The following is a description of a gene set: Mouse Gene Set: GOBP_POSITIVE_REGULATION_OF_CELL_ADHESION Any process that activates or increases the frequency, rate or extent of cell adhesion. studied in species Mus musculus, and this is the list of marker genes: Megf10, Stx3, Ccr2, Hrg, Flna, Ccl19 (NCBI Gene Id 24047), Il2, Dock8, Ptpn23, Pdgfb, Itga6, Cd59b, Pawr, Egflam, Cited2, Sash3, Cd209d, Col8a1, Cxcl12, Cd160, Cd209e, Ldb1, Selenok, Vav1, Sirpa, L1cam, Cd47, Map4k4, Hyal1, Icosl, Ephb4, Ptger4, Lilrb4b, Ccl21a, Rac1, Anxa1, Il15, Ep300 (E1A binding protein p300), Carmil1, Il1b, Dsg2, Kat5, Stat5b, Lep, St3gal4, Cd80, Edil3, Pbrm1, Hspd1 (heat shock protein 1 (chaperonin)), Dnm2, Lif, Tnf, P2ry12, Cav1, Plpp3, Il18, Poldip2, Tfrc, Rela, Itgb3, Fermt2, Socs1, Igfbp2, Mex3b, H2-DMa, Rreb1, Mir326, H2-Eb2, Lamb2, Efemp2, Ccl2, Cd274, Alox15, Il12b, Hsph1, Fstl3, Efnb1, Tbx18, Lilrb4a, Ppm1f, Tnfrsf14, Sox4, Blm, Prkce, Smarca2, Nkap, Hmgb1, Trem1, Ank3, H2-M3, Il12rb1, Tsc1, Gsk3b, Plekha2, Cd44, Nrg1, Myoc, Flot1, Tnfsf14, Ccdc80, Cd36, Ccn1, Il1a, H2-Ob, Dennd6a, Epha4, H2-DMb2, Actl6b, Fadd, Ppp3ca, Dmp1, Tgfb2, Wnt4, Gimap3, Hsp90aa1, Cd86, Bcl10, Arid1a, Erbb2, Gcnt1, Ndnf, Piezo1, Il4i1, Rag1, F11r, Nfkbid, Ninj1, Smarcc2, Fut7, Cxcl13, Iqgap1, P4hb, Smarcd3, Cyth3 (NCBI Gene Id 19159), Icam1, Vsir (NCBI Gene Id 74048), Il4ra, Cd55b, Elane, Xcl1, Jak1, Il6st, Thy1, Emilin2, Dnaja3, Rsu1, Sdc4, Klhl22, Ripk2, Enpp2, Cyrib, Il2ra, Irgm1, Smad7, Pnp, Pdpn, Cd40lg, Dhps, Tnfrsf18, Slc7a1, H2-Ea, Fut1 (fucosyltransferase 1), Kifap3, Sox12, Smarcb1, Ccr7, Disc1, Rnase10, Fgg, Cd1d2, Cd63, Ceacam1 (CEA cell adhesion molecule 1), Arid2, Ccl21e, Igf2, Sec1, Vtn (NCBI Gene Id 22370), Nedd9, Braf, Il7, Shb, Alox5, Tfe3, Pkp2, H2-Ab1 (histocompatibility 2, class II antigen A, beta 1), Tnxb, Ptk2, Ccl21f, Sele, Cd4, Jak3, Rhoh, Cspg5, Bcl6 (B cell leukemia/lymphoma 6), Coro1a, Phf10, Myo10, Cdh13, Cass4, Nr5a2, Ptprc, Il7r, Cd83, Dmd, Ecm2, Ceacam2, Ptprj, Ephb6, Rhod, Dbn1, Tesk1, Adam9, Lamc1, Myadm, Gpam (NCBI Gene Id 14732), Ccr5, Sart1 (squamous cell carcinoma antigen recognized by T cells 1), Il4, Wnt10b, Efnb3, Fmn1, Prkd2, Syk (NCBI Gene Id 20963), Selp, Il12a, Myh9, Btn2a2, Ccl21b, Socs5, Nfat5, H2-T23, Cd244a, Abl1, Lgals9, Cd55, Prkaa1, Mfsd2b, Itgb1, Adgrg1, Afdn, Fermt1, Skint1, Sfn, Npy2r, Fcho1, Bag4, Nr4a3, Egfl6, Spta1, Epha1, Ets1, Src, Rras, Nfkbiz, Apbb1ip, Cdc42, Ptpn22, Spock2, Arpc2, Dock5, Pycard, Il6ra, Brd7, Crkl, Fbln1, Cdh1, Card11, Cd46, Cib1, Smarcc1, Angpt1, Ihh, Pik3r2, Btnl2, Pkp3, Utrn, Nodal, Cd24a, S100a10, Lims1, Frmd5, Zp3, Agr2, Pck1, Cd276, Crk, Il36b, Rell2, Ccl28, Skap1, Prex1, Tjp1, Plaur, Wnt3a, Kif26b, Actl6a, Arl2, Il3, Slamf1, Podxl, Dusp10, Nck1, Ccl21d (C-C motif chemokine ligand 21D), Cd3e, Has2, Atm, Ager, Rasgrp1, Flot2, Kitl, Irf1, Zbtb1, Smarce1, Rap1gap, Col26a1, Pik3r6, Cd27, Ptn, Cd59a, Rock1, Bmi1, Calr, Jak2, Cd28, Itga5, Lamb1 (NCBI Gene Id 97822), Gcnt2, Nck2, Stk4, Ap3b1, Il23a, Dab2, Itgb1bp1, Egr3, Triobp, Il2rg, Cfl1, Abi3bp, Lama1, Tnfsf4, Nckap1l, Ilk, Foxp3, Cbfb, Lef1, Smarca4, Tnfsf18, Thbs1, Lgals1, Itgal, Abl2, Emilin1, Pld2, H2-DMb1, Brd2, Cripto, Cd81, Zfp609, Vnn1, Ibsp, Cyld, Runx3, Lims2 (LIM and senescent cell antigen like domains 2), Gata3, Rhoa, Chrd, Pde4d, Fn1, Epb41l5, Chst2, Ada, Foxc2, Spn, Dusp26, Tsc2, Tnfsf13b, Fbln2, Ptpn11, Cdk6, Bad, Rin2, Il1rl2, Smarcd1, Itpkb, Mip, Aif1, Smarcd2, Epb41l4b, Zmiz1, Pdcd1lg2, Ptk2b, Nrp1, Tgfb1, Shh, Irak1, Dag1, Npnt, Smoc1, Itga3, Tgfbr2 (transforming growth factor, beta receptor II), Cx3cl1, Ptpn6, Carmil2, Foxf1, Zbtb7b, Ret, Ptpru, Adk, Foxo3, Smad3, Cd209c, Ywhag (tyrosine 3-monooxygenase/tryptophan 5-monooxygenase activation protein, gamma polypeptide), Fga, Spp1, Emp2, Hes1, Icos, Lgals8, Calca, Brd4, Rasal3, Pcsk5 (NCBI Gene Id 18552), Prkcz, Lck (NCBI Gene Id 16818), Igf1, Tgm2, Dpp4, Zap70, Nlrp3, Tpm1, Bmp7, Tnfrsf13c, Cd74, Lama2, Dicer1, Magi1, Prkcq, Opa1, Itgb2, Pkp1 (plakophilin 1), Gp1ba, B2m, Hlx, Chst4, Klhl25, Tyk2, Sox2, Npy, Rps3, Tnfsf9, Cd6, Ctsg, Unc13d (NCBI Gene Id 70450, unc-13 homolog D), Apoa1, Stx4a, Wnt5a, Zfhx3 (zinc finger homeobox 3), Kdr, Itga4, Prkca, H2-Eb1, Efnb2, Htr2a, Capn1, Jup, Cd1d1, Mmrn1, Traf6 (NCBI Gene Id 99098), Rac3, Col16a1, Cd5, Dysf (dysferlin), Adam19, Rara, Xbp1, Fbxo38, Ccdc88b, Csf1, Nid1, Fut4, Olfm4, Itga2, Ptafr, Gfus, Itgav, Epo, C1qbp, Vit, Stat5a, Vcam1, Tmem102, Ifng, Ambra1, Hsd17b12, Tnfsf11, Ccl25, Sox13, Ift74, Smoc2, Fgb, Runx1, Hacd1, Malt1, Tek (TEK receptor tyrosine kinase), Vwc2, Adam8, Actb, Gimap5, Tespa1, Ccl5, Vtcn1, H2-Aa, H2-Oa, Havcr2, Vav3, Gli3, Slc4a1, Mdk (midkine), Il6, Il21, Ap3d1, Vegfa, Dock1, Apc